The following is a description of a gene set: Any process that activates or increases the frequency, rate or extent of execution phase of apoptosis. Human Gene Set: GOBP_POSITIVE_REGULATION_OF_EXECUTION_PHASE_OF_APOPTOSIS species: Homo sapiens, and this is the list of marker genes: CXCR3, CASP9, TNFRSF1A, PTGIS, HTRA2, TP53, FAP, NDUFA13, ZC3H12A, CASP8, FADD, BOK, DLC1, TP53BP2, MIR15A, CASP10, SIRT2, HTR2A, RIPK1, HSPD1